The following is a description of a gene set: Any process that modulates the frequency, rate or extent of apoptotic cell clearance. species: Mus musculus Mouse Gene Set: GOBP_REGULATION_OF_APOPTOTIC_CELL_CLEARANCE, and this is the list of marker genes: Cd300lf, Ccl2, Hmgb1, C2 (complement C2), Trem2, Tgm2, Abca7, C3 (complement component 3)